Given this list of marker genes ELOC, TP53 (NCBI Gene Id 7157), BCDIN3D, ELAVL1, LINC-ROR (long intergenic non-protein coding RNA, regulator of reprogramming), FMR1, IL6, ELOB, ZMPSTE24, ZC3H10, DND1, TENT2 (terminal nucleotidyltransferase 2), ADAR, OIP5-AS1, ZSWIM8, STAT3, LIN28B, HOXB-AS3, LIN28A (NCBI Gene Id 79727), here is a description of the gene set: Human Gene Set: GOBP_NEGATIVE_REGULATION_OF_POST_TRANSCRIPTIONAL_GENE_SILENCING species: Homo sapiens Any process that decreases the frequency, rate or extent of the inactivation of gene expression by a posttranscriptional mechanism.